Given this list of marker genes PRKACG, GNAS, ADCY9, PRKACB, AVP, AQP2, AVPR2, PRKACA, ADCY6, ADCY3, here is a description of the gene set: species: Homo sapiens AVP-V2R-PKA signaling pathway. Pathway ID: N00915. Pathway type: Reference. Pathway class: nt06326 AVP signaling. Pathway Definition from KEGG: AVP -> AVPR2 -> GNAS -> ADCY3/6/9 -> cAMP -> PKA -> AQP2 Human Gene Set: KEGG_MEDICUS_REFERENCE_AVP_V2R_PKA_SIGNALING_PATHWAY